Given this list of marker genes Slc26a11, Slc35b2, Slc26a2, Slc26a1, here is a description of the gene set: part of: Glycosaminoglycan metabolism studied in species Mus musculus electronically inferred by orthology from the curated human pathway Reactome Pathway: Transport and metabolism of PAPS This event has been computationally inferred from an event that has been demonstrated in another species.<p>The inference is based on the homology mapping from PANTHER. Briefly, reactions for which all involved PhysicalEntities (in input, output and catalyst) have a mapped orthologue/paralogue (for complexes at least 75% of components must have a mapping) are inferred to the other species.